The following is a description of a gene set: Human Gene Set: GOMF_GUANYLATE_KINASE_ACTIVITY Catalysis of the reaction: ATP + GMP = ADP + GDP. studied in species Homo sapiens, and this is the list of marker genes: MAGI3, GUK1, LRGUK, DLG2, CASK, CARD11 (caspase recruitment domain family member 11), MPP1, DLG1, TJP2